Given this list of marker genes SIX1, SNCA, GJB2, STEAP1, COL7A1, LGR6, WNT6, LTB4R2, GPNMB, DGKH, PTGES, CAMK1D, DCN, C16orf74, MEIS1, PROM1, SOSTDC1, HLA-B, KRT15, HSPA2, TSHZ2, CYP2S1, PAX9, DLK1, NRG1, NLRP1 (NCBI Gene Id 82286), S100A2, SPARCL1, TIMP1 (NCBI Gene Id 7076), CSTA, HS3ST1, CD40, TNFSF10, FHL2, OPTN, COL6A2 (collagen type VI alpha 2 chain), DAPL1, A4GALT, MARVELD1, BHLHE40 (NCBI Gene Id 8553), DMRT2 (doublesex and mab-3 related transcription factor 2), SGK1, EDN1, CYP4X1, PSPH, COL1A2, FAM107A, PKP1, WNT4 (NCBI Gene Id 54361), SLC20A2, ALOX15, RASSF6, WNT10A, LMO2, TNFAIP8 (TNF alpha induced protein 8), ISL1, EMP1, CYP2W1, FAT2, EVA1C, SFN, LPAR6, LSP1, ADAM28, MAFB, KLF2, IL1RAP, SERPINB5, CAPNS2, STING1, IFITM1, LGALS7B, EDARADD, VCAN, DLK2, ABI3BP, FMO1, IFI16, CD82, PAPSS2, CLDN10, F3, PRNP, FHL1, FRZB, SOX15, KLK10 (kallikrein related peptidase 10), EYA1, GCLC, CXCL1, PITX1, NDUFA4L2, RAPGEF5, SYNPO2, GNG11, PNCK, EHF (NCBI Gene Id 26298), EPAS1, CH25H, SPINK5, ADGRF1, IRAG2, NTF3, FOSL1, FBXO32, KRT14, TP73, MUC20, DKK3, LGALS1, PLAT, DST, SH3BP1, MEG3, PCP4L1, PART1, HCAR2, SLITRK6, CHST9, KISS1, KRT5, RARRES2, IGFBP4, PFKP, NUPR1, CDCP1, SCNN1B, SERTAD4, NPPC, LYPD6B, BAALC, EMP3, CLDN1, MYC, MMP10, TP63, KLK11, PRRG4, EYA2, CX3CL1, GLIS3, NBL1, GADD45G, KRT13, MFAP4, OTX1, FXYD5, ACKR3, CFH, HCAR3, IGFBP3, CXCL6, COL17A1, ITGB4, TGFB1, ADH7, BOC, LGALS7, LINC01644, CDKN1A (cyclin dependent kinase inhibitor 1A), TMPRSS4, TFPI2, LRP4, A1BG, TRIM29, IL33, COL14A1, GNG12, TGFBI, TPM2, ANXA1, MUC4 (mucin 4, cell surface associated), SLC2A9, SLC15A2, TNNT3, NR4A2, NRXN3 (neurexin 3), GRAMD2B, ELN, SCNN1G, RETREG1, SERTAD4-AS1, SULF2, GPC3, EHD2, LARP6, ST6GALNAC2, SLPI, NXPH4, SEMA3A, TFAP2A, STXBP6 (NCBI Gene Id 29091), NMRK1, here is a description of the gene set: from publication He P, Lim K, Sun D, Pett JP, Jeng Q, Polanski K, Dong Z, Bolt L, Richardson L, Mamanova L, Dabrowska M, Wilbrey-Clark A, Madissoon E, Tuong ZK, Dann E, Suo C, Goh I, Yoshida M, Nikolić MZ, Janes SM, He X, Barker RA, Teichmann SA, Marioni JC, Meyer KB, Rawlins EL (PMID 36493756) Proximal basal Human Gene Set: HE_LIM_SUN_FETAL_LUNG_C1_PROXIMAL_BASAL_CELL studied in species Homo sapiens